Given this list of marker genes MINDY1, ABCA12, FAM241A, THYN1, TCEAL8, MAN1A1, EFNB2, VAV3, CDKN2B, here is a description of the gene set: studied in species Homo sapiens Genes bound and repressed by ZNF217 in MCF7 cells (breast cancer). Human Gene Set: THILLAINADESAN_ZNF217_TARGETS_DN The ZNF217 oncoprotein is a constituent of a core transcriptional complex that includes CoREST, histone deacetylase 1/2, lysine demethylase 1, and the C-terminal binding protein 1/2. We have combined genome-wide expression profiling and chromatin immunoprecipitation with directed selection and ligation (ChIP-DSL) to identify a subset of genes directly regulated by ZNF217. Our results establish p15(ink4b) as a direct target of the ZNF217 complex. Downregulation of ZNF217 in MCF-7 breast cancer cells resulted in a dramatic increase in p15(ink4b) expression and coincided with increases in dimethylation of H3-K4 and, surprisingly, a decrease in K9/K14-H3 acetylation. Stimulation of HaCaT cells with transforming growth factor beta (TGF-beta) resulted in a release of ZNF217 and a concomitant binding of SMAD2 to the proximal promoter, which preceded increases in ink4b protein expression. Furthermore, the changes in chromatin marks at the p15(ink4b) promoter following TGF-beta stimulation were similar to those observed following ZNF217 downregulation. Collectively, these results establish the ZNF217 complex as a novel negative regulator of the p15(ink4b) gene and may constitute an important link between amplification of ZNF217 and the loss of TGF-beta responsiveness in breast cancer. from publication Thillainadesan G, Isovic M, Loney E, Andrews J, Tini M, Torchia J (PMID 18625718)